Given this list of marker genes SLC9A9, SLC9A4, SLC9A1, SLC39A1, SLC30A3, SRI, SLC39A7, SLC39A6, SLC39A8, SLC30A5, SLC40A1, SLC39A4, SLC8A3, SLC9A6, SLC8A1, CP, SLC39A5, SLC24A2, SLC41A1, SLC9A7, SLC8A2, SLC30A2, SLC30A1, SLC31A1, SLC11A2, SLC9A2 (NCBI Gene Id 6549), SLC9A5, SLC24A5, SLC24A1, SLC9A3, CALM1, SLC30A10, SLC24A3, SLC30A8, SLC39A10, SLC9A8, SLC39A3 (NCBI Gene Id 92729), SLC11A1, SLC39A2, SLC24A4, SLC8B1, SLC39A14, HEPH, SLC41A2, here is a description of the gene set: studied in species Homo sapiens part of: SLC-mediated transmembrane transport Reactome Pathway: Metal ion SLC transporters Six SLC gene families encode proteins which mediate transport of metals. The families are SLC11, SLC30, SLC31, SLC39, SLC40 and SLC41 (He L et al, 2009; Bressler JP et al, 2007).